The following is a description of a gene set: electronically inferred by orthology from the curated human pathway part of: HDR through Homologous Recombination (HRR) or Single Strand Annealing (SSA) This event has been computationally inferred from an event that has been demonstrated in another species.<p>The inference is based on the homology mapping from PANTHER. Briefly, reactions for which all involved PhysicalEntities (in input, output and catalyst) have a mapped orthologue/paralogue (for complexes at least 75% of components must have a mapping) are inferred to the other species. Reactome Pathway: HDR through Homologous Recombination (HRR) species: Mus musculus, and this is the list of marker genes: Top3a, Mre11a (NCBI Gene Id 17535), Rfc1, Pold1, Rps27a, Pole2, Gen1, Pold2, Ubb, Kat5, Palb2 (partner and localizer of BRCA2), Pcna, Firrm, Rad51b, Rpa1, Pole, Rfc3, Rbbp8 (NCBI Gene Id 225182), Bard1, Fignl1, Blm, Xrcc3, Nbn, Pold4, Polh, Brca1, Mus81, Wrn, Dna2, Slx1b, Slx4, Rad51c, Polk, Brca2, Rad51ap1